The following is a description of a gene set: Median longitudinal ear length greater than two SD above the mean determined by the maximal distance from the superior aspect to the inferior aspect of the external ear. species: Homo sapiens Long ear Human Gene Set: HP_LONG_EAR, and this is the list of marker genes: STT3A, WNT7A, KDM3B, EIF5A, DPYD, EED